The following is a description of a gene set: Human Gene Set: GOBP_MACROPHAGE_CHEMOTAXIS The movement of a macrophage in response to an external stimulus. species: Homo sapiens, and this is the list of marker genes: EDNRB (endothelin receptor type B), RPL13A, SLAMF1, CKLF, CMKLR1, SFTPD, CSF1R, CCL2, TRPV4, C3AR1, MAPK1, AZU1, NUP85, PTPRJ, PTK2, CX3CL1, TAFA4, MDK, TNFSF18, MMP28, EDN2, CSF1, MAPK3, DDT, C5, CYP19A1, THBS1 (NCBI Gene Id 7057), AKIRIN1, C5AR1, STAP1, MSTN, CXCL17, RARRES2, SLAMF8, SAA1, MMP2, CCL3, MTUS1, CCL5, MIF, LGALS3 (NCBI Gene Id 81625), PTK2B, IL34